Given this list of marker genes Tor1a, Edem1, Tmem67, Sdf2, Sdf2l1, Stub1, Clu, Hspa5, Bag6, Dnajc10, Hspa1a, Dnajb11, Lonrf2, Dnajb9, Eif2ak3, Dnajc3, Hdac6, here is a description of the gene set: Mouse Gene Set: GOMF_MISFOLDED_PROTEIN_BINDING Binding to a misfolded protein. species: Mus musculus